The following is a description of a gene set: studied in species Homo sapiens Human Gene Set: TRAVAGLINI_LUNG_ARTERY_CELL from publication Travaglini KJ, Nabhan AN, Penland L, Sinha R, Gillich A, Sit RV, Chang S, Conley SD, Mori Y, Seita J, Berry GJ, Shrager JB, Metzger RJ, Kuo CS, Neff N, Weissman IL, Quake SR, Krasnow MA (PMID 33208946), and this is the list of marker genes: PPP1R14A, PDCD4, ARGLU1, GATA6, FAM107A, EFNB2, CALCRL, F8, CLIC3, PLTP, EXOC6, KAZALD1, IFI6, ENTPD1, CTTNBP2NL, MECOM, GIMAP7, EPS8, NOS1, RND3, GFOD1, SLC7A2 (NCBI Gene Id 6542), KCTD12, LTBP1, GIMAP8, SSTR1, IL33, CXCL2, CKB, LTBP4, GJA5 (gap junction protein alpha 5), PLK2, ADAM15, GIPC2, FNBP1, TM6SF1, ARHGAP4, TMEM120A, SERPINE2, DKK2, ATP13A3, OCIAD2, ARHGDIB, FGF18, THSD7A, PIR, LIFR, HSD17B12, HES4, FBLIM1, SEMA3G (NCBI Gene Id 56920), ITGB4, ASRGL1, TSPAN2, TSPAN7, CTSC, HERPUD1, AZIN1, MT1E, SMAD6, SRPX, IGFBP3, LPCAT2, IL11RA, SULF1, PALLD, CYYR1, NPR3, RUNX1T1, GIMAP1, ITPR2, ZFAND5, JAM2, CTDSPL, ATP1A1, SRP14, LIMA1, PROCR, IFITM1, PTPRR, MGP, HIF1A, SELP, GLUL (NCBI Gene Id 2752), KCNMB4, TACC1, SEC11C, HS6ST1, SLC15A3, PGRMC2, NPDC1, RNASE1, SRGN, FBLN5, RNF144B, ABI3BP, TRABD2A, SOX4, F2R, CTNNAL1, CDC42EP3, PRKX, VEGFA (NCBI Gene Id 7422), PCSK5, BMX, PTGIS, IFI44L, PLLP, SOX17 (SRY-box transcription factor 17), MYLIP, PALMD, PLA2G5, CLDN10, PNRC1, FN1, TMEM245, RASGEF1B, PIK3C2B, MMRN2, TOX2, CXCL12, AIF1L, CFAP36, FBLN2, PLCG2, ENPP2, PLAC9, PTPRB, HEY1, STMN1 (stathmin 1), TIPARP